Given this list of marker genes CTDP1, PHF13, YIPF3, DNAJA3, IL10RB, COMTD1, CLCN5, CREB3L2, ARL15, ADCK1, ASPA, MTAP, MOB3B, IGSF8, RRS1, MMP19, TMEM87B, CBR1, PRRC1, RIC1, MAPK1IP1L, UBXN6, RPE, SLC35F5, PDXDC1, PLEKHA2, PLPP1, EEA1, KIAA1191, BBS5, BLNK (NCBI Gene Id 29760), CTNND1, CCDC6, TCF7L2, CRIP2, CAMSAP2, AKR1B1, CRBN, SUDS3, LRRC58, LARP4B, EIF3G, CFLAR, SCLY, PHOSPHO1 (phosphoethanolamine/phosphocholine phosphatase 1), TSPAN14, ABHD12, BCL2A1, KGD4, EXOC8, SPACA1 (NCBI Gene Id 81833), LIMK1, ANXA7, USP22 (NCBI Gene Id 79397), C3orf33, MEAK7, NFE2L1, ACAA2, MAN2C1, ARHGAP5, PTGES2, DAP, CDYL, CCL25, CRELD2, ETV3, PPP1R1B, CPT2, OSTM1, UBA5, MTX2, DNAJC10, KMT5B, ZPR1, CLDN12, ACLY (NCBI Gene Id 47), LMNA, PRPSAP2, PTK2, RMND5A, MTM1, ESYT1, NLRP10, ANO6, ALDH1B1, KMT5A, SLC27A1, KLF10, HPS6, MGAT4B, SYS1, RAB11FIP5, SDC1, UQCC1, RRAS2, SEPTIN11, DCAKD, REM1, PTPRS, RAB8B, RCBTB1, PARD6A, SOAT1, CEP162, ATP6V1A, WDR74, SOCS6, SOCS2, PPP4R3B, RRAS, RBM47, AFF1 (NCBI Gene Id 83116), MGAT5, CTBS, LDAF1, SLC17A5, USP19, SNX5, BAIAP2, ELMO2, IARS1, RPF2, NDUFA13, TCIRG1, CDC14B, TAFA3, GMPR, PTGS1, TNIP2, PHACTR3 (NCBI Gene Id 85418), CHMP5, CDKN2A, NAP1L4, SS18, CAST, SEMA4B, GAK, SPAG9, SEPTIN10, CD44, ACSS1, FZD1, SS18L2, XPR1, LDLRAD3, AMZ1 (archaelysin family metallopeptidase 1), SYNE2, C1GALT1C1, GNG11, MARS1, NUS1, BLOC1S6, CRYBG3, REPIN1, CASP9, PCBP2, SLC2A1, RAB11FIP2, VEZT, HCCS, ZKSCAN5, TCF25, SLC1A4, CYB5R1, TMEM230, RDH14, ORC4, TMEM62 (transmembrane protein 62), ATP6V1H, CD300C, UBA1, STK24, CDKN2B, PIK3CA, NAA35, MIEF1, SOAT2, HMG20B, ETFDH (NCBI Gene Id 2110), CD68, P3H1, DAGLA, KLHDC9, BAZ2B, CLOCK, MCOLN1 (mucolipin TRP cation channel 1), FYTTD1, UGDH, AK8, SUGT1, PLA2G15, OSGIN2, SLC15A3, ETFB, TMTC3, PROS1, ABHD13, SLC46A3, FPGT, CDADC1, here is a description of the gene set: Genes up-regulated in bone marrow-derived macrophages: untreated (0 min) versus IL10 and LPS (180 min). Human Gene Set: GSE5589_UNSTIM_VS_180MIN_LPS_AND_IL10_STIM_MACROPHAGE_UP IL-10 or IL-6 stimulation of control 129xC57BL/6 murine bone marrow derived macrophages in the presence of LPS. We used microarrays to detail the global programme of gene expression changes in response to IL-6 or IL-10 stimulation in the presence of lipopolysaccharide. BMDMs were isolated from control, IL-6-/-, and IL-10-/- mice on a 129XBL/6 mixed background mice and differentiated in the presence of CSF-1 for 6-7 days. Cells were scraped and plated in 6 well plates at 2x10e6/well. Cells were washed with complete DMEM and rested for 1-2 hr before stimulation with combinations of IL-10 (10 ng/ml), IL-6 (2 ng/ml) or LPS (100 ng/ml) for 45 min or 180 mins. Complete biological replicates were performed. species: Homo sapiens from publication El Kasmi KC, Holst J, Coffre M, Mielke L, de Pauw A, Lhocine N, Smith AM, Rutschman R, Kaushal D, Shen Y, Suda T, Donnelly RP, Myers MG Jr, Alexander W, Vignali DA, Watowich SS, Ernst M, Hilton DJ, Murray PJ (PMID 17114459)